Given this list of marker genes SPIC, LAMC1, TMEM150A, AUH, CRYZ (NCBI Gene Id 1429), KCNAB1, KHK, DLG3 (discs large MAGUK scaffold protein 3), GSX1, FSTL1, PRR15, SLX9, HLA-DMA (NCBI Gene Id 3108), DPP7, CELF4, SURF4, CYTH3, TCF7L1, GCSAM, POLR2C, MCAM (melanoma cell adhesion molecule), TNFRSF4, BAAT, SFRP2, SPMAP2, CANX, ZNF292, PROX1, MYCL, RUNX1T1, FAM171A1, WDR55, SCN7A, ANXA3, CXCR5, FASLG, KRT27, TM4SF1, WNK2, ALOXE3 (arachidonate epidermal lipoxygenase 3), CEP250, PLOD3, PTPRJ, VAMP5, VNN1, DOCK7, GAPDHS, GTF3C4, CXCR2, CKMT1B, PRL, RPRD1B, CSRP1, HMGA2, HOXD10, PLA2R1, SAPCD1, GCM2, GRM8, ATP5MF, MYRF, TG, ART1, FLT3, ADGRG1, HOXC6, PTPRA (protein tyrosine phosphatase receptor type A), GRIA1, WFS1, CCDC28B, ZNF821, ITGAV, MKI67, ELK1, NELFE, SLC27A4, KCNU1, EGR2, LY75, TERF1, HAO2, NAB2, H1-4, ALCAM, KCTD9, NDUFB4, CD244, CKMT2, GAMT, CCR6, LITAF, CSF1, CCRL2, PRRC1, GATA1, SGO1, RGS16, SLC4A8, ERCC5, PERP (p53 apoptosis effector related to PMP22), IL1RN, SCGB1A1, TMEM214, OSMR, FKBP10, MYO6 (myosin VI), CUBN, EEA1, IFIH1 (NCBI Gene Id 64135), AHR, IL10, SLC3A1 (solute carrier family 3 member 1), ACADVL, RPS14, LGMN, HSD3B7, LRP10, STRA6, BLK, BCL2L11, PARP1, ZNF35, YAP1, SPOCK1, HOXB8, TWSG1, MMP14, SHMT2, APOBEC2, NEFH, GPM6B, DHRS7B, PRDM1 (PR/SET domain 1), MRPS2, VMP1, ETV1, PAWR, CCDC93, TMEM266, EFNB3, IFI27L2, LAT2, IMMT, DDIT4, PTMS, PLSCR1, FLNA, ENTPD1, PTPN11, ADCY6, NAT2, CISH, TLR7, GDNF, AARD, CD22, LHPP, CTSE, SLC4A7, CELA1, ADAM7, GZMB, XCR1, CLIC4 (chloride intracellular channel 4), PTCH1, LY86, COCH, AFP, ATP5IF1 (ATP synthase inhibitory factor subunit 1), ACKR3, MRPL48, TLN1, BCL3, TBL1X, H1-5, TFDP1, GPD2, SYPL1, CFH (NCBI Gene Id 3076), IL1A, SEC14L1, WIZ, EPCAM, HIF1A, HSPA4L, SPOCK2, MAP2, SPRR2A, SELP, EOMES, CORO2B, BTK, NDUFS4, CFHR2, ST6GALNAC2 (ST6 N-acetylgalactosaminide alpha-2,6-sialyltransferase 2), MC5R, MS4A1, AOPEP, MFHAS1, LCLAT1, here is a description of the gene set: from publication Wherry EJ, Ha SJ, Kaech SM, Haining WN, Sarkar S, Kalia V, Subramaniam S, Blattman JN, Barber DL, Ahmed R (PMID 17950003) Human Gene Set: GSE9650_EXHAUSTED_VS_MEMORY_CD8_TCELL_UP studied in species Homo sapiens Genes up-regulated in comparison of exhausted CD8 T cells versus memory CD8 T cells. CD8 T cells normally differentiate from resting naïve T cells into function effector and then memory CD8 T cells following acute infections. During chronic viral infections, however, virus-specific CD8 T cells often become exhausted. We used microarrays to examine the gene expression differences between naive, effector, memory and exhausted virus-specific CD8 T cells following lymphocytic choriomeningitis virus infection.